The following is a description of a gene set: Human Gene Set: GOBP_DNA_METHYLATION_DEPENDENT_CONSTITUTIVE_HETEROCHROMATIN_FORMATION Formation of constitutive heterochromatin by a pathway that includes methylation of genomic DNA such as CpG islands. species: Homo sapiens, and this is the list of marker genes: HDAC1, PIWIL4, EZH2 (NCBI Gene Id 392834), SMARCA5, MBD3, TDRD1, SIRT1, MBD2, DDX4 (DEAD-box helicase 4), TDRD5, KMT2A, TDRD12, CTCF, TDRD9, BEND3, MOV10L1, TRIM28, PIWIL2, SPOCD1, MBD3L5, MBD3L3 (methyl-CpG binding domain protein 3 like 3), ATF7IP, BMI1, ZNF304, MAEL, DNMT3L, EHMT2, MBD3L1, MBD3L2B, SETDB1, HELLS, FKBP6, C19orf84, MBD3L2, DNMT1, SPIN1, BAZ2A, DNMT3A, EHMT1, TEX15, MBD1, MBD3L4, PPM1D